Given this list of marker genes Glo1, Gnb1, Aldh7a1, Kcnh1, Spg21, Ighm, Mrpl48, Folh1 (NCBI Gene Id 53320), Snhg6, 4833420G17Rik, Vps52, Ncs1, Alad, Bcat2, Tcea1, Spock1, Srp9, Usp38, Tulp3, Rfk, Eef1akmt1, Pdpn, Sspn, Acaa1a, Nphp1, Kcnj9, 1810037I17Rik, Dcaf8, Slc15a2, Tpm4, Krt12, Ccl21a, Pttg1, Grk5, Tpbg, Pdxdc1, Prdx2, Psmb6, Ccnd2, 2410018L13Rik, Cd6, Hjurp, Grin2b, Ccnd1, Rpp14, Ocel1, Scoc, Tox4, Tubgcp4, Snhg11, Akap1, Zfp68, Ociad1, Sc5d, Cpsf2, Mtif2, Sorl1, Cop1, Ppdpf, Ackr1, Myo7a, Psmb5-ps, Cap1, Mapre1, Fam32a, Abhd14a (NCBI Gene Id 68644), Ssbp4, Scg5, Pou2f1, Thumpd1 (NCBI Gene Id 233802), Pam, Phlda1, Rgs16, Aldh9a1, Per3, Serpina3n, here is a description of the gene set: studied in species Mus musculus Best cis-regulated quantitative trait loci (QTLs) in the mouse genome which modulate transcription in brain tissue. Mouse Gene Set: CHESLER_BRAIN_QTL_CIS Patterns of gene expression in the central nervous system are highly variable and heritable. This genetic variation among normal individuals leads to considerable structural, functional and behavioral differences. We devised a general approach to dissect genetic networks systematically across biological scale, from base pairs to behavior, using a reference population of recombinant inbred strains. We profiled gene expression using Affymetrix oligonucleotide arrays in the BXD recombinant inbred strains, for which we have extensive SNP and haplotype data. We integrated a complementary database comprising 25 years of legacy phenotypic data on these strains. Covariance among gene expression and pharmacological and behavioral traits is often highly significant, corroborates known functional relations and is often generated by common quantitative trait loci. We found that a small number of major-effect quantitative trait loci jointly modulated large sets of transcripts and classical neural phenotypes in patterns specific to each tissue. We developed new analytic and graph theoretical approaches to study shared genetic modulation of networks of traits using gene sets involved in neural synapse function as an example. We built these tools into an open web resource called WebQTL that can be used to test a broad array of hypotheses. from publication Chesler EJ, Lu L, Shou S, Qu Y, Gu J, Wang J, Hsu HC, Mountz JD, Baldwin NE, Langston MA, Threadgill DW, Manly KF, Williams RW (PMID 15711545)